Given this list of marker genes DLG3, CASD1 (CAS1 domain containing 1), ALAS1, PEX6, AMBRA1, HDAC5, GTPBP2, RHOQ, IVNS1ABP, PCYOX1, ARHGAP31, PPP1R10, SHFL, TMCC3, UBR1, CTTNBP2NL, SMAD7, MYO7A, MDM2, SEMA3G, ZDHHC24, PEAK1, DPP7, ITM2C, SMIM1, GPATCH1, EIF1, DPH2, TAF1C, USP30, POLRMT, PPP1CC, KLHL18, TTC8, YPEL2, GMPR, SLC22A17, PLOD1, LRPAP1, ZNF467 (zinc finger protein 467), ADPRM, ERLIN2, MAN2A2, TBC1D17, P3H4, CALHM2 (NCBI Gene Id 51063), TSEN34, C19orf44, DHX34, YPEL3, WIZ, SPINT1, FNTA, GLB1, EEA1, YARS1 (tyrosyl-tRNA synthetase 1), DEXI, FAM168B, LONRF1, MIER2, IFI27, GPR160, CRK, LAMP2, RNPEPL1, CSRNP2, IL21R, FERMT3, IQSEC2, SLC3A2, MAST3, FAM53B (family with sequence similarity 53 member B), TOM1, SMAD5, ATAT1, TMEM9B, SNTA1, TCTA, DDX3X, TOR4A, RERE, RCN2, PSEN1, ALDH3A2, AFTPH, ZNF771, ST6GALNAC4, KIAA0319L, NCOA5, RAD50, KIAA0753, GARIN4 (NCBI Gene Id 149647), CIAO1, FARP1, AKTIP, ANKS3, TCF4, CANT1, MZT2B, RRP1B, TMEM50A, TRAF2, UNC93B1, BRI3, ASB4 (NCBI Gene Id 51666), AAGAB, GPD1L, TP53I13, ATP9B, IGFBP4, ARL8B, ZNF703, ZNF658, GLIS3, PHACTR4, NUPR1, ZNF76, STAMBPL1, TRAPPC14, MTMR3, KLF10, MESD, KLHL7, VPS37B, FCRL1, NFRKB, LAYN, ATP6V0B, TP53INP2, CHD7, ARHGAP35, ZNF445, TENT5C, SOS2, TNFRSF1B, PRPS2, NOP2, ULK2, EXOG, SYTL3, PDZD8, DOCK1, CALU, RHOC, STRN3, C11orf54, FHIP2A, H3-5 (NCBI Gene Id 440093), GBP7, CHAMP1, TENT4B, ROGDI, TRAPPC2B, NFIX, CUL1, POMT1, KLF7, SIPA1, NCKAP5L, TMEM243, OGA, PREX1, USP8, PCBP4, SPATS2, RETREG3, IKZF1, VPS18, TOGARAM1, IRF2BPL, ZBTB4, RNF180 (ring finger protein 180), DDX5, DNAJC12, MPHOSPH9, NUDT4, DDIT3, ELMOD2, SFT2D1, ZBTB18, TBL2, ABCG2, FZD8, MMACHC, AJUBA, TTC17, BANK1, DHODH, ZNF777, NFYC, CTNND1, LDLRAD4 (low density lipoprotein receptor class A domain containing 4), CD151, SCAMP2, MT1E, TBPL1, IL7R, DDA1, MARS1, NECTIN2, here is a description of the gene set: Human Gene Set: GSE26351_UNSTIM_VS_WNT_PATHWAY_STIM_HEMATOPOIETIC_PROGENITORS_UP Analysis of mobilized peripheral blood CD34+ cells from a healthy volunteer under erythroid differentiation conditions with and without stimulation to the BMP or Wnt signaling pathways. For erythroid differentiation, expanded CD34+ cells were placed in Stemspan SFEM medium supplemented with 2% pen/strep, 20ng/ml SCF, 1U/ml Epo, 5ng/ml IL3, 2uM dexamethasone, and 1uM beta-estradiol. Arrays were performed 2 hours after addition of cytokines. For signaling pathway stimulation, cells were exposed to 0.5uM BIO (a GSK3 inhibitor) for Wnt pathway activation, 25ng/ml rhBMP4 for BMP pathway activation, or vehicle control for 2 hours. Three biological replicates were performed per treatment group. We used microarrays to detail the global program of gene expression changes after Wnt or BMP pathway stimulation in human CD34+ hematopoietic progenitors under erythroid differentiation conditions. studied in species Homo sapiens from publication Trompouki E, Bowman TV, Lawton LN, Fan ZP, Wu DC, DiBiase A, Martin CS, Cech JN, Sessa AK, Leblanc JL, Li P, Durand EM, Mosimann C, Heffner GC, Daley GQ, Paulson RF, Young RA, Zon LI (PMID 22036566) Genes up-regulated in CD34+ cells: control versus treated with GSK-3 Inhibitor IX (BIO).